The following is a description of a gene set: from publication Chen Y, Wang X (PMID 31504780) Genes predicted to be targets of miRBase v22 microRNA mmu_miR_669i in miRDB v6.0 with MirTarget v4 prediction scores > 80 (high confidence targets). studied in species Mus musculus Mouse Gene Set: MIR_669I, and this is the list of marker genes: Fbxl14, Crppa, Pcdh10, Kcnmb2, Hecw2, Fyttd1, Tmc1, Cap1, Etnk1, Dennd6a, Hnmt, Nwd1, Add3, Ccnh, Mcee, Cry1, Etv1, Naalad2 (N-acetylated alpha-linked acidic dipeptidase 2), Apbb2 (amyloid beta precursor protein binding family B member 2), Kcnv1, Fbxl17, Stxbp5l, Epha4, Luc7l3, Lman2l, Kcna4, Calr4, Kif21a, Aldoc, Slc6a1, Srsf10, Vash2, Elf2, Sh3kbp1, Mfsd6, Tshz1, Caps2, Kdsr, Dtna, Tspan12, Stx8, Pdp1, Tceal1, Dact1, Cep152, Tmprss11a, Tex12, Pgr, Ube2e1, Guf1, Mindy2, Rab7, Srsf11, Rest, Taf1b, Btc, Cd36, Nbea, Zfp354b, Klhl5, Gpr22, Tagap, Dr1, Slc25a2, Plp1, Atad2, Sri, Atad2b, Dnm3, Tg, Gpm6a (NCBI Gene Id 234267), Ltv1, Extl3, Slc44a3, Adgre4, Fgf12, Yeats2, Neurod4, Adamts5, Klhdc2, Slc35f4, Nrg3, Cdh7, Bmal1, Caprin1 (NCBI Gene Id 99144), Matr3, Zfp521, Traf3ip1, Paxbp1 (NCBI Gene Id 67367), Hs3st5, Cep135, Azin1, Foxj3, Cysltr1, Rngtt, Lhfpl6, Sbno2, Mbp, Rictor, Ndst4, Ssbp2, Btg3, Tmppe, Nfia (NCBI Gene Id 68838), Bcl11a, Gucy2f, Tyr, Ntf3 (NCBI Gene Id 30909), Agfg1, Plin3, Porcn, Pik3c2g, G3bp2, Nlgn1, Ccp110, Cyth3, Prkcb, Ceacam19, Ptbp1, Ankrd42, Bpnt2, Fli1, Tbx3, Slitrk5, Peli1, Syt14, Bmpr1a (bone morphogenetic protein receptor, type 1A), Rtn4rl1, Crtc1, Kbtbd7, Pip4p2, Cnksr2, Zfhx4 (NCBI Gene Id 80892), Nbl1, Rtp1, Dennd1b, Csrnp1, Pdlim5, Zfp763, Prkab2, Adam10, Cntn4, Adgrl3, Ankrd6, Plscr4, Dnajb3, Slc52a2, Fryl, Fam184b, Slc6a19, Tagap1, Tbr1, Lsamp, Supt7l, H2-M10.6, Ino80d, Otx2, Gm6377, Seh1l, Spock3, Gabrb3, Rab2b, Apobec3 (apolipoprotein B mRNA editing enzyme, catalytic polypeptide 3), Armc8, Plpbp, Rap2c, 9230112D13Rik, Kcnc4, Zfpm2, Mbtd1, Six6, Cav1, Slain2, Cxadr, Dapk1, Lrriq3, Zfp711, Fech, Tpcn1, Bcl2, Elmod1, Cpeb2, Pde4d, 1700010I14Rik, Jakmip2, Stt3a, Dpp4, Kctd9, Wrnip1, Btbd8, Map3k8, Yipf6, Gatm, Cdk19, Pcdh7, Atosa, Fermt2